Given this list of marker genes SERPINB11, SLCO1B3, CRIM1, AGT, SPINK8, SPINK5, COL6A3, SERPINI2, A2M, SERPINB10, ANOS1, WFDC6, SPINK14, SERPINB13, SERPINH1, ITIH1, WFDC8, EPPIN, SPINK2, AMBP, WFDC1, SERPINA2, SPOCK1, SLCO1B7, SERPINE3, SERPIND1, SERPINA3 (NCBI Gene Id 95022), ANXA2, SLPI, SERPINF2, ITIH6, PI3 (NCBI Gene Id 5266), WFDC2, SERPINA4, SERPINC1, SPINK13, PAPLN, PEBP1, WFDC13, SERPINA9, SPINK9, SERPINB4, SERPINB2, WFDC9, APLP2, SPINT2, PZP, SPINK7, SERPINB12, ITIH5, SERPING1, APP, SERPINE1, SPINK4, SERPINA7, HRG, SERPINA12, SERPINA6, SERPINB6, WFIKKN1, CPAMD8, WFDC10A, HMSD, SPINK1, COL28A1, SERPINA5, CD109, FURIN, SPINK6 (serine peptidase inhibitor Kazal type 6), A2ML1, WFDC10B, ITIH2, SERPINA11, RECK, TFPI, ITIH4, SERPINB9, SPINT4, SERPINB1, SERPINE2, SLCO1B3-SLCO1B7, MANSC4, SERPINA1, SERPINF1, COL7A1, WFDC11, SERPINB5, SERPINB8, SERPINB3, PCSK1N, SERPINA10, TFPI2, ITIH3, SPINT1, WFDC5, SERPINI1, SERPINB7, SPINT3, WFDC3, WFIKKN2, WFDC12, here is a description of the gene set: Binds to and stops, prevents or reduces the activity of a serine-type endopeptidase. studied in species Homo sapiens Human Gene Set: GOMF_SERINE_TYPE_ENDOPEPTIDASE_INHIBITOR_ACTIVITY